Given this list of marker genes Psmc6, Psmc2, Mul1, Psmd13, Prdx1, Psmd6, Ufd1, Psma7 (proteasome subunit alpha 7), Psmc4, Psma3, Psmb5, Psmc5, Ubb, Mafk (NCBI Gene Id 17135), Psma2, Ep300, Vcp, Psmb7, Cul1, Psmb4, Psma4, Psmc3, Psma5, Psmb6, Psmd1, Map1lc3b, Psma6, Sesn2, Psma1 (proteasome subunit alpha 1), Rps27a, Sqstm1, Psmd12, Psmd7, Psmc1, here is a description of the gene set: studied in species Mus musculus Reactome Pathway: KEAP1-NFE2L2 pathway This event has been computationally inferred from an event that has been demonstrated in another species.<p>The inference is based on the homology mapping from PANTHER. Briefly, reactions for which all involved PhysicalEntities (in input, output and catalyst) have a mapped orthologue/paralogue (for complexes at least 75% of components must have a mapping) are inferred to the other species. electronically inferred by orthology from the curated human pathway part of: Cellular response to chemical stress